The following is a description of a gene set: from publication Bedogni F, Hevner RF (PMID 34321999) Genes selectively expressed by postmitotic neurons beginning in the intermediate zone, in most cases extending into the cortical plate of embryonic day 14.5 mouse cortex. Mouse Gene Set: HEVNER_INTERMEDIATE_ZONE_AND_UP_POSTMITOTIC_NEURONS studied in species Mus musculus, and this is the list of marker genes: Chd3, Cabp1, Ctif, Lrp11, Cdk5r1, Cd24a, Celf2, Zeb2, Dnajc6, Aplp1, Gng2, Mllt11, Mir124a-1hg, Wnk2, Rtn2, L1cam, Mllt3, Hectd4, Nyap1, Gng3, 6430548M08Rik, Bicd1, Parp6, Ctnna2, Shkbp1, Gpr85, Hdac2, Actl6b, Rab3a, Cnih2, Bcl11b, Atxn10, Map2, Mapk8, Klf7, Lrch2, Celf3, Bcl11a, Tmeff1, Ndrg4, Gpm6a, Nicn1, Syp, Shb, Atcay, Dpysl3, Bdh1 (NCBI Gene Id 71911), Apc, Pcyt1b, Zfta, Clmp, Tes, Celsr3, Map1b, Ccser1, Kif5c, Npr2, Dclk1, 9330159F19Rik, Paqr3, Unc5b, Lratd1, Atp2b2, Svop